The following is a description of a gene set: studied in species Mus musculus Mouse Gene Set: GOBP_REGULATION_OF_HEMOGLOBIN_BIOSYNTHETIC_PROCESS Any process that modulates the frequency, rate or extent of the chemical reactions and pathways resulting in the formation of hemoglobin, an oxygen carrying, conjugated protein containing four heme groups and globin., and this is the list of marker genes: Klf4, Abcb10, Fech (NCBI Gene Id 14151), Slc6a9, Eif2ak1, Ldb1, Slc25a37